The following is a description of a gene set: Human Gene Set: GOBP_CANONICAL_NF_KAPPAB_SIGNAL_TRANSDUCTION species: Homo sapiens An intracellular signaling cassette characterized by the I-kappaB-kinase (IKK)-dependent activation of NF-kappaB, also known as the canonical NF-kappaB signaling cascade. The cascade begins with activation of a trimeric IKK complex (consisting of catalytic kinase subunits IKKalpha and/or IKKbeta, and the regulatory scaffold protein NEMO) and ends with the regulation of transcription of target genes by NF-kappaB. In a resting state, NF-kappaB dimers are bound to I-kappaB proteins, sequestering NF-kappaB in the cytoplasm. Phosphorylation of I-kappaB targets I-kappaB for ubiquitination and proteasomal degradation, thus releasing the NF-kappaB dimers, which can translocate to the nucleus to bind DNA and regulate transcription. The canonical NF-kappaB pathway is mainly stimulated by proinflammatory cytokines such as IL-1beta, tumor necrosis factor (TNF)-alpha, antigen ligands, and toll-like receptors (TLRs)., and this is the list of marker genes: HSPB1, EP300, TLR4, TLR7, RHOC, LTBR, LRRC19, KLF4, PPP2CB, DEFB124, ZDHHC17, TRIM59, RELB, UBD, NDFIP2, TLR6, SIRT1, TNFRSF19, LTB, CLEC4D, TRIM25 (tripartite motif containing 25), CCR7, LTA, NFKBIB, MIER1, MIR195, MIR199A1, PLEKHG5, RIPK2, NUP62, ROR1, CD36, BIRC2, TNFRSF10B, IRAK3, ECT2, CCL21, NOD1, MIR15A, IRAK4, PIDD1, DDX21, GBP7, CARD11, TFG, OLFM4, RIOK3, NR1D1, OTUD7B, HUWE1, USP10, DDRGK1, MIR365A, TNFSF15, PYCARD (PYD and CARD domain containing), TRIM52, ECM1, CX3CR1, AZI2, WNT5A, MAP3K3 (mitogen-activated protein kinase kinase kinase 3), LILRB4, PRDX1, TLR3, RBX1, PRKCB, BIRC3, SLC20A1, S100A4 (S100 calcium binding protein A4), TLR8, GPR89A, FBXW11, RHOH, WDR83, TGFBR3, IRAK2, F2RL1, MIR140, TRIM5, DNAJA3, LGALS1, USP20, DHX36, SPHK2, EDNRA, CARD14, CLEC6A (NCBI Gene Id 93978), GJA1, TRAF6, NFKBIA, CFLAR, MIR497, CASP10, NFAT5, CUL1 (cullin 1), ZFAND6, HTR2B, LIMS1, MAPKBP1, JMJD8, SLC44A2, TRIM38, VAPA, SLCO3A1, PER1, RASSF2, TMC8, TRAF1, HLA-DRB1, TIFAB, CD40LG, TANK, NAMPT, PRKD1, PPM1B, ZMYND11, LURAP1L, MAS1, IFIT5, APOL3, TICAM2, STAT3, ANKRD17, CLEC7A, MIR146A, MIR21, FLOT1, WLS, INS, CPNE1, CCDC22, SPI1, ILK, TLR2, IKBKG, TRAF2, TRAF5, ANXA4, TERF2IP, TNFAIP3, BST2, GSTP1, HACD3, ESR1, LITAF, CREBBP (NCBI Gene Id 1387), TLE1, PRKN, NDFIP1, EDA2R, RIPK1, NLRP12, EDNRB, TRIM8, IRAK1BP1, EDAR, ATP2C1, DHX15, ARRB2, SIVA1, RBCK1, CX3CL1, SHARPIN, TRAF3IP2, LPAR1 (lysophosphatidic acid receptor 1), TNFSF11, CARD10, UBE2I, OPTN, TMEM101, ABL1, PPM1A, TFRC, UFL1, BTK, TREM2, IL1B, SBNO1, TRIM32, PINK1, TNIP1, CARD9, AKAP13 (NCBI Gene Id 84122), PLCG2 (NCBI Gene Id 5336), PARP1, BCL10, ANGPT1, CD200, TMED4, MIR30C2, NFKB2, TGFB1, TRADD, TNF, LTF, IKBKB, RNF31, SHISA5, TRAF4, CD74, PSMA6, RHOA, TRIM13, CASP8, ITCH, TMEM106A, IRGM (NCBI Gene Id 345611), TMEM9B, INSR, STAT1, FKBP1A, PELI2, ERC1, TRIM22, EDN1, CAV1, PPP5C, TNIP2, LURAP1, LAMTOR5, IL1R1, HMOX1, SLC35B2, TRIM39, MUL1, NKIRAS1 (NCBI Gene Id 57083), MYO18A, MIR15B, IL1A, PPM1N, FLOT2 (flotillin 2), MALT1, MAP2K5, MID2 (midline 2), REL, UNC5CL, SLC39A8, CHRNA7, CD4, CC2D1A, CYLD, NFKB1, TAB2, RELA, ADIPOQ, MYD88, SIRPA, LIME1, PYDC1, NEK6, ZC3HAV1, CAPN3, MIR27A, S100A13, S100A12, UBE2N, PIM2, UBE2V1, ALPK1, TRIM62, TNFSF14, MTDH, CD40, FLNA, TICAM1 (TIR domain containing adaptor molecule 1), INAVA, CACTIN, CARD8, XIAP, NLRP6, CARD16 (NCBI Gene Id 114769), SECTM1, PELI1, CCL19, NLRX1, TAB3, FAF1, MAP3K7, GAPDH, PLK2, FASLG, SNIP1, TNIP3, MIR138-1, IKBKE, ZC3H12A, BTRC, NR1H4, PRL, SQSTM1, CANT1, ZNF675, VEGFA, CASP1 (caspase 1), MIB2, TMSB4X, DDX1, BCL3, TNFRSF1A, LGALS9, TBK1, CTH, F2R, NLRC3, TNFRSF11A, IRF3, C18orf32 (chromosome 18 open reading frame 32), PIAS4, AJUBA, MAVS, EDA, MIR16-1, ZDHHC13, PDPK1, HDAC1, TLR9, S100B (NCBI Gene Id 6285), GPRC5B, SUMO4, BRD4, NOD2, TAX1BP1, RORA, CXXC5, FADD, TIFA, NKIRAS2, TSPAN6, IRAK1, DAB2IP, IFT80, CHUK (NCBI Gene Id 1147), TIRAP, NR2C2, PRDX4, GOLT1B, TNFSF10, ADAM8, CARD19, NFKBIL1, PRKCE, TRAF3